Given this list of marker genes Tmem8b, Rd3, Gad1, Krt33a, Dhrs9, Rhobtb1, Adipor1, Cyp2c23, H2-M10.5, Kcnq5, Ralgapa1, Ywhaq, Ccdc71l, Pdgfra, Lyve1, Snd1, Ctdsp2, Cavin2, Scara3, Exoc8, Apol7c, Mecp2, Tmem184b, Rfk, Bbs9 (Bardet-Biedl syndrome 9), Krtap31-1, Aamp, Cdh4, Ablim1, Kpna6, Apol7a, Sv2b, Prokr2, Psen1, Neu3, Serpinf2, Nras, Zmat2, Gcnt1, Pitpna, Grm5, Psg25, Rabl2, Commd8, Sptan1, 4931406C07Rik, Atp1b2, Slc25a23, Zim1, Xaf1, Cnr2, Daam2, Gjc3, Kcng3, Tox, Zfp94, Dtna, Gkn2, Srl, Larp1, Col6a5, Clasp2, Mmp20, Fam53c, Cybrd1, Sgo1, Bmp2, Fgfr2, Fbxo28, Gtf3c2, Nfia, Hspa13, Galnt9 (polypeptide N-acetylgalactosaminyltransferase 9), Exosc9, Sptlc3, Cps1, Fhit, Minar2, Zmynd11, Grid1, Rab1b, Prpf3, Ppm1f, Smc3 (NCBI Gene Id 13006), Chd3, Rusc1, Neurod4, Dctn6, Acadm, Tyrp1, Elf2, Psme3, Foxn2, Agrn (agrin), Il20ra, Lepr, Pafah2, Bcap29, Dnajc11, Mtf1, Cntn5, Gata6, Pfpl, Zfp410, Eda2r, Scp2, Tafa1, Gstm6, Ppp1r1c, Cd38, Srcin1, Gpr173, Timp3, Slc16a5, here is a description of the gene set: from publication Chen Y, Wang X (PMID 31504780) species: Mus musculus Genes predicted to be targets of miRBase v22 microRNA mmu_miR_6404 in miRDB v6.0 with MirTarget v4 prediction scores > 80 (high confidence targets). Mouse Gene Set: MIR_6404